The following is a description of a gene set: studied in species Mus musculus Mouse Gene Set: GOBP_POSITIVE_REGULATION_OF_OSTEOBLAST_DIFFERENTIATION Any process that activates or increases the frequency, rate or extent of osteoblast differentiation., and this is the list of marker genes: Lrp3, Pdlim7, Mir210, Scube3, Cebpa (CCAAT/enhancer binding protein alpha), Fam20c, Nppc, Ddr2, Gli3, Acvr2a, Prkd1 (NCBI Gene Id 18760), Cd276, Wnt10b, Men1, Acvr2b, Bmp6, Gdf10, Gdpd2, Cebpd, Gnas, Scube2, Bmp2, Bmpr1b, Wnt7b, Dlx5, Fgf2, Bmpr1a, Ifitm1, Lmna, Ccn4, Sfrp2, Lrp5, Ilk (NCBI Gene Id 16202), Wnt4, Ctnnb1, Prmt3, Cthrc1, Acvr1, Fbn2, Bmpr2, Runx2, Ptger4, Ccn1, Ifi204, Jund, Ctnnbip1, Mir3960 (NCBI Gene Id 100628606), Ppp3ca, Hey1, Nell1, Jag1, Bmp4, Dnai3, Cebpb, Fbxo5, Zhx3, Sox11, Tmem119, Yap1, Ffar4, Msx2, Fermt2 (NCBI Gene Id 218952), Smad1, Wnt3, Igf1, Npnt, Il6st, Bmp7, Clic1, Smad5, Il6, Ltf, Trp63, Suco, Tent5a, Fzd1, Vegfa, Mef2c, Atraid, Wwtr1